The following is a description of a gene set: from publication Chen Y, Wang X (PMID 31504780) Mouse Gene Set: MIR_509_5P Genes predicted to be targets of miRBase v22 microRNA mmu_miR_509_5p in miRDB v6.0 with MirTarget v4 prediction scores > 80 (high confidence targets). studied in species Mus musculus, and this is the list of marker genes: Ky, Peg10, Gm5591, Specc1, Ube3b, Bmpr1b, Ash2l, Sacm1l, Sgpl1, Trp53inp2, Ism1, Kcnn1, Trpd52l3, Dyrk3, Cep350, Golph3, Coa8, Slx4ip, Igsf3 (NCBI Gene Id 78908), Rora, Slc22a22, Jarid2, Mapkbp1, Skint4, Wfdc3, Dsg1c, Emp1, Zbtb33, Krtap6-5, Nfib, Zfp229, Rnf139, Kifc2, Kcna2, Myrf, Uap1, Synj1, Grm5, Itga6, Fam168a, Rad23a, Cd109, Pgm5, Trpc4, Usp1, Slc25a42, Efcc1, Tmed5, Slmap, Pigq, 1700016H13Rik, Epc1, Nos3, Tpd52l1, Wdr37, Tnks, Lrrc39, Seh1l, Rapgef4, Chdh, Krt20, Dusp13a, Osr1, Tmem8b